Given this list of marker genes PRPH2 (peripherin 2), ISOC1, C2orf69, UBOX5, ZNF619, TRO (NCBI Gene Id 7216), BASP1, PDE4A, GSPT1, INO80, PLET1 (NCBI Gene Id 349633), STEEP1, KCNH1, HSPBP1, RAB3C, FPGT, ZNF704, KREMEN1, ASAP1, MDGA1, PIP4P2, TRAPPC3L, GSTM5, VPS29, ARL5A, ZNF493, CASTOR3P, ABLIM1, SBF2, TCFL5, GARS1, CRIM1, TDRD1, UTP3, SPECC1, CCDC85A, PCGF3, LIN7C, ZNF532, STXBP5, RAB2A, VLDLR, KRT2, CALM1, GPRASP1, GPA33, TMEM135, SASH1, IPMK, RAD51AP1, PRKAR2A, GAB3, ZNF365, ZNF488, SGPP2, PKLR, GALNT16, KSR2, ERI2, SPOPL, DSE, ELAVL1, RAB30, COL19A1, GCSAM, CYP2S1, DCHS2, TXNL4A, POMK, SEMA6A, NFIB, PKIA, here is a description of the gene set: Genes predicted to be targets of miRBase v22 microRNA hsa-miR-3138 in miRDB v6.0 with MirTarget v4 prediction scores > 80 (high confidence targets). species: Homo sapiens from publication Chen Y, Wang X (PMID 31504780) Human Gene Set: MIR3138